The following is a description of a gene set: The binding of a peptide to the antigen binding groove of an MHC protein complex. Human Gene Set: GOBP_PEPTIDE_ANTIGEN_ASSEMBLY_WITH_MHC_PROTEIN_COMPLEX species: Homo sapiens, and this is the list of marker genes: PDIA3, HLA-DQA1, HLA-DRB4, TAPBPL (NCBI Gene Id 55080), HLA-DQB1, HLA-DPB1, TAPBP, HLA-DQB2, B2M, HLA-DMB, CALR, HLA-DQA2, HLA-DOA, HLA-DRB1, HLA-DRA, HLA-DPA1, HLA-DRB5, HLA-DRB3, HLA-DOB, HLA-DMA, HLA-A